Given this list of marker genes IL21, DCLRE1B, TLR8, IL2RA, JAK3, PRIM1 (DNA primase subunit 1), IRF1, CTNNBL1, FNIP1, FASLG, NFKB2, ELF4, SPI1, ATM, IKZF1, HYOU1 (hypoxia up-regulated 1), UNC119, PTEN, ATP11A, B2M, SP110, MCM10, CARD11, ZBTB24, POMP, HELLS, NCKAP1L, PIK3CD (phosphatidylinositol-4,5-bisphosphate 3-kinase catalytic subunit delta), DOCK8, MYD88, CD3D, TBX2 (T-box transcription factor 2), MS4A1, MYSM1, RIPK1 (receptor interacting serine/threonine kinase 1), IRF2BP2 (NCBI Gene Id 359948), RAG1, POLD1, LRBA, GATA2, IKBKB, CD3G, DCLRE1C, IGHM, GFI1, NFKBIA, SH2D1A, IVNS1ABP, RAG2, BACH2, SOCS1, PLCG2, IL2RG, IKBKG, KNSTRN, PSMB10, TNFRSF9 (TNF receptor superfamily member 9), FCHO1, CBLB, ZAP70, RAC2 (NCBI Gene Id 5880), KDM6A, CASP10, LAT, SLC39A7, ICOSLG, REL, PTPRC, CD81, CD79A (CD79a molecule), RFX5, TOM1, WDR1, KMT2D, BTK, NHEJ1, LYN, TCF3, CD19, SEC61A1, ICOS, SYK, IL6R, CD3E, NBN, LCP2, CD79B, STAT1, XIAP, ALG12, TET2, FAS, CARD9, IRAK4, PRKDC, POLD3, TRNT1, SASH3, CTPS1, ADA, IGLL1 (NCBI Gene Id 8222), ARHGEF1, PRKCD, RASGRP1, CDCA7, MAP3K14, IKZF3, PIK3R1, here is a description of the gene set: A structural abnormality of B cells. Abnormal B cell morphology Human Gene Set: HP_ABNORMAL_B_CELL_MORPHOLOGY studied in species Homo sapiens